The following is a description of a gene set: from publication Chen Y, Wang X (PMID 31504780) Human Gene Set: MIR2681_5P species: Homo sapiens Genes predicted to be targets of miRBase v22 microRNA hsa-miR-2681-5p in miRDB v6.0 with MirTarget v4 prediction scores > 80 (high confidence targets)., and this is the list of marker genes: SOS1, TRAPPC11, TET1, NPR3, PHLDA1, SMCO3, CNKSR2, LIN9 (lin-9 DREAM MuvB core complex component), WRNIP1, SLC30A9, CREBBP, TRIM49D2, HSF5, WWC3, CREM, CDH19, SEMA3E, GNAI1, IL31RA, LRRCC1, SIK2, XKR9, BRDT, SCN2A, PMS1, PTPRE, FCGR1A, SP3, HIPK1, TUT4, RCHY1 (NCBI Gene Id 29027), FABP4, ATRN, JMJD1C, CAMK2D, CACYBP (calcyclin binding protein), FKBP4, CERS6, CCDC71L, ZMYND11, CFAP54, ZFY, GPR22, SANBR, FASN, FBXO11, RPE, CCDC198, ACER3 (alkaline ceramidase 3), BTG2, STYX, TMEM30A, ARPC5, SESN3, ACSL6, ITGB8, NKAIN3, LUC7L2, FASTKD3, CDK6, NAV1, SGIP1, FSD1L, CCDC144NL, AIPL1, RERGL (NCBI Gene Id 79785), TRDN, C2CD2, DPH5, DSC3, BLTP3B, GPSM2, RUNX2, SPACA4, PKDCC, SMC5, SLAIN2, ZSWIM1, BAHCC1, RASEF, TYRP1, FAM114A1, FCGR1BP, PTPRD, PSMA2, PLCG1, LRP1, LATS2, CBLL1, KIAA0825, MEGF9, RNF19A, FAM47E, PDCD2, PAX9, IQCJ (IQ motif containing J), ARID1A, KCNMB2, DOK6, STAT1, DPYSL2, CYB5B, SLC16A7, AKIRIN1, ZFP14, SIAH1, UBE2K (NCBI Gene Id 84819), ZSWIM6, ANGPTL3, ULK2, ANKIB1 (NCBI Gene Id 54467), SLC35F2, ITGA2, PERP, DNAJC3, WT1, PRPF40A, SASH1, STXBP5L, PCDHB13, BORCS7, CACNA2D1 (NCBI Gene Id 781), FZD8, PNN, CNOT2, CALU, LRP2BP, SMNDC1, UBR2, CPSF6, MALRD1, BCL11B, PRICKLE1, FNDC3A, WDR44, SCAF8, ZNF780A, CADM2, SPAST, PDZD8, APELA, ARHGAP5, WIPF1, BID, NUDT21, RNF180, KCNH8, TBL1XR1, ZNF200, USF3, TCEAL9, LRCH2, GCSH, ZHX1, TMEM263, OGN, HTR3D, CCDC59, ZNF749, METRNL, FAM180A (NCBI Gene Id 392794)